Given this list of marker genes Cdk6, Osbpl6, Ccnf, Ddx17, Pgpep1, Frem1 (NCBI Gene Id 329873), Arid1b, Robo2, Cnep1r1, Btbd8, Grin2a, Tgif2, Kctd6, Meioc, Pigv, Dip2c, Gm5134, Rp1, Ep300, Cnot7, here is a description of the gene set: Genes predicted to be targets of miRBase v22 microRNA mmu_miR_7031_3p in miRDB v6.0 with MirTarget v4 prediction scores > 80 (high confidence targets). from publication Chen Y, Wang X (PMID 31504780) studied in species Mus musculus Mouse Gene Set: MIR_7031_3P